Given this list of marker genes Pik3ca, Pkd2, Aqp2, Sipa1, Avpr1a, Plec (NCBI Gene Id 381012), here is a description of the gene set: studied in species Mus musculus Mouse Gene Set: GOBP_CELLULAR_RESPONSE_TO_WATER_STIMULUS Any process that results in a change in state or activity of a cell (in terms of movement, secretion, enzyme production, gene expression, etc.) as a result of a stimulus reflecting the presence, absence, or concentration of water.